The following is a description of a gene set: Human bone stromal cells, after three-dimensional coculture with human prostate cancer (PCa) cells in vitro, underwent permanent cytogenetic and gene expression changes with reactive oxygen species serving as mediators. The evolved stromal cells are highly inductive of human PCa growth in mice, and expressed increased levels of extracellular matrix (versican and tenascin) and chemokine (BDFN, CCL5, CXCL5, and CXCL16) genes. These genes were validated in clinical tissue and/or serum specimens and could be the predictors for invasive and bone metastatic PCa. These results, combined with our previous observations, support the concept of permanent genetic and behavioral changes of PCa epithelial cells after being either cocultured with prostate or bone stromal cells as three-dimensional prostate organoids or grown as tumor xenografts in mice. These observations collectively suggest coevolution of cancer and stromal cells occurred under three-dimensional growth condition, which ultimately accelerates cancer growth and metastasis. Genes up-regulated in metastatic vs non-metastatic stromal cells originated from either bone or prostate tissues. from publication Sung SY, Hsieh CL, Law A, Zhau HE, Pathak S, Multani AS, Lim S, Coleman IM, Wu LC, Figg WD, Dahut WL, Nelson P, Lee JK, Amin MB, Lyles R, Johnstone PA, Marshall FF, Chung LW (PMID 19047182) studied in species Homo sapiens Human Gene Set: SUNG_METASTASIS_STROMA_UP, and this is the list of marker genes: TMEM263, IGIP, AKR1C1, TRIO (NCBI Gene Id 7204), SOCS5, GSPT1, IFI6, DKK1, COL5A1, SEC24D, SLC16A1, CDC42EP3, KRT34, SEL1L3, LURAP1L, ASS1, LMO4, CALR, PRRG2, EDEM1, EIF1AY, RDH10, SNX1, FABP5, FBLN2, SPSB1, PPIB, EMC10, STK38L, SCD, P4HA1, ANXA4, GOLM1, CNN3, FZD8 (NCBI Gene Id 8325), FHL1, PTPRS, SVEP1, HEXIM1, ADAM10, CD55, ANOS1, TMEM47, PINK1, PRRC2B, MGAT3, JUNB, HSPG2, TKT, AGRN, SNAI2, TNC, EIF2B3, RAF1, PROS1, CPEB2, ALCAM, COL3A1, PSD3, THBS2, PLOD1, U2AF2, TUSC3, XYLT1, PDIA5, SPARC, PTGFRN (prostaglandin F2 receptor inhibitor), ALDH3B2, JMY (junction mediating and regulatory protein, p53 cofactor), MAPK1, CLDN11, LARP6, COL12A1, RFX5 (regulatory factor X5), PLK2, VCAN, BNIP3L, CD81, CDH6, DUSP6, PLOD2, CD276, HMGCS1, CTDSP2, TIMP3, EPS8, DHRS1, PTGS2, PLAAT4, H2AC6, CKB, CLIP2, CD59, ETV5, UACA, CRABP2, SSX2IP (NCBI Gene Id 22892), NEAT1, MAP3K8, CD46, VMP1, ALOX5, GAA, SEC13, COL5A2, FURIN, SDC4, KCNK1, THY1, DCBLD2